The following is a description of a gene set: species: Homo sapiens part of: Synthesis of substrates in N-glycan biosythesis Dolichyl-phosphate-glucose functions as a donor of glucose groups in reactions including three steps of N-glycan precursor biosynthesis. Dolichyl-phosphate-glucose itself is synthesized from UDP-glucose and dolichol phosphate on the cytosolic face of the endoplasmic reticulum membrane, then flipped to the luminal surface of that membrane. Reactome Pathway: Synthesis of dolichyl-phosphate-glucose, and this is the list of marker genes: ALG5, NUDT14 (NCBI Gene Id 256281)